The following is a description of a gene set: Human Gene Set: HP_ABNORMAL_FORAMEN_MAGNUM_MORPHOLOGY Any abnormality of the foramen magnum. Abnormal foramen magnum morphology studied in species Homo sapiens, and this is the list of marker genes: FGFR3, ELN, FBLN5, GPSM2, FLNA (filamin A), IARS2, CHD4, FLNB, HNRNPH1, RAB23, INPPL1, RUNX2, ANKH (ANKH inorganic pyrophosphate transport regulator, NCBI Gene Id 7995), RSPRY1, LBR, ALDH18A1, EP300, CREBBP